The following is a description of a gene set: Any process that stops, prevents or reduces the frequency, rate or extent of epithelial cell apoptotic process. species: Homo sapiens Human Gene Set: GOBP_NEGATIVE_REGULATION_OF_EPITHELIAL_CELL_APOPTOTIC_PROCESS, and this is the list of marker genes: MDK, PRKAA1, MIR182, BCL2, PKHD1, RB1, CDKN1B, PRKAA2, NPC1, NUPR1, NKX2-5, HAND2, CFLAR, SERPINB13, NEUROD1, NKX2-6, SRSF6, ADAR, TMF1, ITGB3BP, PPARA, PDX1, TCF7L2, YAP1, WFS1, BTC, ATOH1, CAST